The following is a description of a gene set: species: Mus musculus The chemical reactions and pathways resulting in the breakdown of purine nucleoside, one of a family of organic molecules consisting of a purine base covalently bonded to a sugar ribose (a ribonucleoside) or deoxyribose (a deoxyribonucleoside). Mouse Gene Set: GOBP_PURINE_NUCLEOSIDE_CATABOLIC_PROCESS, and this is the list of marker genes: Enpp4, Ahcy, Gda, Urad, Xdh, Uox, Ada, Adal, Nudt1, Pnp, Ahcyl (adenosylhomocysteinase like), Pnp2, Urah (NCBI Gene Id 76974)